The following is a description of a gene set: species: Homo sapiens RUNX1 regulates expression of components of tight junctions Human Gene Set: REACTOME_RUNX1_REGULATES_EXPRESSION_OF_COMPONENTS_OF_TIGHT_JUNCTIONS, and this is the list of marker genes: TJP1, CBFB, RUNX1, CLDN5, OCLN